The following is a description of a gene set: The compaction of chromatin located adjacent to the CENP-A rich centromere 'central core' and characterized by methylation of histone H3K9, into heterochromatin, resulting in the repression of transcription at pericentric DNA. Human Gene Set: GOBP_PERICENTRIC_HETEROCHROMATIN_FORMATION studied in species Homo sapiens, and this is the list of marker genes: HELLS, H3-3A, H3-3B, CENPV, SIRT6